Given this list of marker genes HRAS (NCBI Gene Id 338029), MAP2K1, MAP2K2, MAPK3, KRAS, ARAF, GRB2, SOS2, NRAS, SOS1 (NCBI Gene Id 7838), BRAF, MET, CCND1, MAPK1, RAF1, here is a description of the gene set: Human Gene Set: KEGG_MEDICUS_VARIANT_MUTATION_ACTIVATED_MET_TO_RAS_ERK_SIGNALING_PATHWAY Pathway Definition from KEGG: MET* -> GRB2 -> SOS -> RAS -> RAF -> MEK -> ERK -> CCND1 Mutation-activated MET to RAS-ERK signaling pathway. Pathway ID: N00005. Pathway type: Variant. Pathway class: nt06263 Hepatocellular carcinoma. studied in species Homo sapiens